Given this list of marker genes ATP1B1 (ATPase Na+/K+ transporting subunit beta 1), ATP1A1, ATP12A, ATP1A4, ATP4A, ATP4B, ATP1A2, ATP1A3, here is a description of the gene set: Enables the transfer of a solute or solutes from one side of a membrane to the other according to the reaction: ATP + H2O + K+(out) = ADP + phosphate + K+(in). species: Homo sapiens Human Gene Set: GOMF_P_TYPE_POTASSIUM_TRANSMEMBRANE_TRANSPORTER_ACTIVITY